The following is a description of a gene set: species: Homo sapiens Any process that increases the rate, frequency or extent of a necroptotic process, a necrotic cell death process that results from the activation of endogenous cellular processes, such as signaling involving death domain receptors or Toll-like receptors. Human Gene Set: GOBP_POSITIVE_REGULATION_OF_NECROPTOTIC_PROCESS, and this is the list of marker genes: CASP6, MIR107, RIPK3, MIR103A1, PARP1, ZBP1 (Z-DNA binding protein 1), AIFM1, RIPK1